The following is a description of a gene set: studied in species Mus musculus Mouse Gene Set: GOBP_BUNDLE_OF_HIS_DEVELOPMENT The process whose specific outcome is the progression of the bundle of His over time, from its formation to the mature structure. The bundle of His is part of the His-Purkinje system that transmits signals from the AV node to the cardiac Purkinje fibers., and this is the list of marker genes: Irx3, Nkx2-5, Tbx3, Tbx5, Id2